The following is a description of a gene set: Mouse Gene Set: WP_PROSTAGLANDIN_SYNTHESIS_AND_REGULATION studied in species Mus musculus Prostaglandin synthesis and regulation, and this is the list of marker genes: Hpgd, Ptgs1, Hsd11b1, Ptger3 (NCBI Gene Id 19218), S100a10, Ptgdr, Ptger2, S100a6, Anxa4, Ptgir, Ptgs2, Ptgds, Anxa8, Hsd11b2, Anxa2, Anxa5, Edn1, Scgb1a1, Anxa6, Ednra, Pla2g4a, Ptger4, Ptger1, Anxa3, Ednrb, Anxa1, Cyp11a1, Ptgfr, Tbxas1, Prl